Given this list of marker genes PURA, POLA1, ORC4, CDT1, CIZ1, GINS3, ORC2, ORC5, CCNE2, MCM7, CCNE1, ORC1, LRWD1, MCM4, NOC3L (NOC3 like DNA replication regulator), MCM2, GMNC, PRIM1, KAT7, CDC6, MCM3, ORC3, MCIDAS, PRIM2, ORC6, CDK2, TICRR, MCM6, RPA4, CDC34, TOPBP1, CDC45, MCM5, WRNIP1, MCM10, POLA2, GMNN, NBN, here is a description of the gene set: species: Homo sapiens The process in which DNA-dependent DNA replication is started; it begins when specific sequences, known as origins of replication, are recognized and bound by the origin recognition complex, followed by DNA unwinding. Human Gene Set: GOBP_DNA_REPLICATION_INITIATION